The following is a description of a gene set: studied in species Homo sapiens Pathway Definition from KEGG: FANCD2+FANCI+Ub -> BRCA1+BARD1 == BRIP1 == BRCA2+PALB2+DSS1 == RPA == HROB+MCM8+MCM9 Human Gene Set: KEGG_MEDICUS_REFERENCE_HOMOLOGOUS_RECOMBINATION_IN_ICLR Homologous recombination in ICLR. Pathway ID: N01466. Pathway type: Reference. Pathway class: nt06508 Interstrand crosslink repair., and this is the list of marker genes: BARD1, RPA2, BRIP1, FANCI, BRCA1, RPA1, FANCD2, BRCA2, PALB2, HROB, MCM9, SEM1, RPA3, MCM8 (minichromosome maintenance 8 homologous recombination repair factor), UBB, RPA4